Given this list of marker genes PIK3CB, PIK3R1, PIK3CA, PIK3CG, PIK3R5, PIK3R6, PIK3R2, PIK3R3, PIK3CD, here is a description of the gene set: A phosphatidylinositol 3-kinase complex that contains a catalytic and a regulatory subunit of a phosphatidylinositol 3-kinase (PI3K) enzyme, plus one or more adaptor proteins. Class I PI3Ks phosphorylate phosphatidylinositol, phosphatidylinositol-4-phosphate and phosphatidylinositol-4,5-bisphosphate, and are divided into subclasses A and B according to the type of adaptor subunit with which they associate. The class I PI3K subfamily of genes comprises members in vertebrates, worm and fly, but none in yeast. studied in species Homo sapiens Human Gene Set: GOCC_PHOSPHATIDYLINOSITOL_3_KINASE_COMPLEX_CLASS_I